Given this list of marker genes HDGF, NUDT4, GYPA, GLRX5, GYPE, CTSE, ERMAP, MARK3, CDC27, TRAK2, FECH, HTRA2, HMBS, KLF1, BNIP3L, PSMD9, TOP1, GCLM, SLC22A4 (solute carrier family 22 member 4), RBX1, RCL1, BLVRB, SPTB, TFRC, EIF1AY, SPTA1, RHCE, DCUN1D1, XK, CROCCP2, CA2, ANK1, TFDP1, RAD23A, MAP2K3, TAL1, SELENBP1, RHAG, RBM38, MINPP1, ALAD, TRIM10, EPB42, RPIA, GYPC, GYPB, XPO7 (NCBI Gene Id 23039), SLC4A1, DNAJC9, UROD, EIF2AK1, HBQ1, ALAS2, UBAC1, NARF, PPOX, AHSP, DCAF11, GCLC, FBXO7, here is a description of the gene set: Human Gene Set: GNF2_CDC27 Neighborhood of CDC27 cell division cycle 27 in the GNF2 expression compendium Neighborhood of CDC27 studied in species Homo sapiens